Given this list of marker genes WDR20 (NCBI Gene Id 91833), VCP, TIFAB, TANK, TGFB1, WDR48, DMWD, here is a description of the gene set: Human Gene Set: GOMF_DEUBIQUITINASE_ACTIVATOR_ACTIVITY Binds to and increases the activity of a deubiquitinase. studied in species Homo sapiens